The following is a description of a gene set: Any process that modulates the frequency, rate or extent of neurotransmitter receptor activity involved in synaptic transmission. Modulation may be via an effect on ligand affinity, or effector function such as ion selectivity or pore opening/closing in ionotropic receptors. species: Mus musculus Mouse Gene Set: GOBP_REGULATION_OF_POSTSYNAPTIC_NEUROTRANSMITTER_RECEPTOR_ACTIVITY, and this is the list of marker genes: Shisa9, Cacng7, Begain, Shisa7, Shisa6, Homer1, Nrxn2, Homer3, Notch1, Dlgap2, Cacng4, Neto1, Lrp8, Chrna5